The following is a description of a gene set: species: Homo sapiens Human Gene Set: HP_EEG_WITH_SPIKE_WAVE_COMPLEXES EEG with spike-wave complexes Complexes of spikes (<70 ms) and sharp waves (70-200 ms), which are sharp transient waves that have a strong association with epilepsy, in cerebral electrical activity recorded along the scalp by electroencephalography (EEG)., and this is the list of marker genes: HCN1, MTOR, GOSR2 (golgi SNAP receptor complex member 2), GNAO1, PIGT, SIK1 (salt inducible kinase 1), PGAP3, SCN1B, CLCN2, SAMD12, KCNC2, CACNB4, GABRD, GRIN1, KCNMA1, SYNGAP1, PIGL, SCN8A (NCBI Gene Id 6334), SLC32A1, SETD1B, CACNA1H, GRIN2A, AKT3, TRIM8, CDKL5, SLC25A22, CASK, CHAT, SLC5A7, DMXL2, STARD7 (StAR related lipid transfer domain containing 7), PIK3CA, PSAT1, PGAP2, STX1B, PRRT2, SRPX2, SCN9A, PRNP, SCN2A, NEXMIF, SLC18A3, APC2, CSTB, YWHAG, AASS, ADGRG1, GABRA1, SPTAN1, SCN1A, AP2M1, PIGO, MYO9A (myosin IXA), NEUROD2, PI4KA, ADGRV1, PIGP, AGRN, PIGQ, FGF13, SCARB2, PNKP, PIGY, TBC1D24, KCNQ3, EFHC1, PAFAH1B1, ARX, PIGV, CILK1, GABRG2, SYT2, CHD2, VAMP1, SLC2A1, PIGW, SLC25A1, SYT1, SNAP25, CPA6, PRICKLE1, JRK, GRM7, YEATS2, COL13A1, SLC6A1, KCNA2, GABRB3, KCNA1